Given this list of marker genes TTC28, ADTRP, LGALS3BP, LDOC1, MEGF6, MCF2L (MCF.2 cell line derived transforming sequence like), PIM2, CSGALNACT1 (chondroitin sulfate N-acetylgalactosaminyltransferase 1), ACVR2A, AKR1C1, DGKA, RAB3GAP1, C14orf132 (chromosome 14 open reading frame 132), PVT1, KANSL1L, R3HDM4, SASH1, KLF7, EEIG1, CREB3L1, FOXO1, CHMP7 (NCBI Gene Id 91782), ACVR2B, TRIB2, TNFRSF4, CRYAB, PTGIR, GPHN, IL6ST, EDAR, VAT1, MINDY1, LIMK2, IL1RAP, RPS6KA5, MORC4, BSDC1, EOLA2-DT, GAL3ST4, MEOX1 (NCBI Gene Id 4222), CTSB, ENGASE, CPA2, SLC16A5, PLAC4, NDRG2, TRAF3IP2, WNT7A, NPC2, ADGRE1, CFP, GPA33, LECT2, EEF1G, CORO1B, MAP3K3, EPS8, LTB, LGR5, FAM13A, CFAP44, ITGA6, RERE, VIPR1, LEF1, MAST4, N4BP1, MEIS3P1, EPHA1, RFPL3, MAN1C1, TPCN1, FHIT, C1orf105, LY96, PHKA2, EPHB6, PIM1, GABBR1, PLP2, PPEF2, SEMA3G (semaphorin 3G), HKDC1, TIAM1, ARHGEF11, FABP4, PLPP1, SSBP2, SLC8B1, FAXDC2, DPP4, TESPA1, RCAN3, FBLN5, DACT1, PDE4DIP, BCL2 (NCBI Gene Id 596), ICA1, EPHX2, CCR6, IDUA, TBC1D4, GPRASP1 (NCBI Gene Id 9737), SGSH, CLTCL1, LIMS2, GPR183, SIRT3, CYSLTR1, TAF4B, SELL, SPICE1, CCNI, PFKM, ZC4H2, KBTBD11, CRIP2, ACVR1, SULT1B1, COL4A3, KCNN1, TPD52L1, OBSL1, PDE8A, SLC22A17, MSRA, BIRC3, C6orf120, INF2, DDR1, NUMA1, CEP85, ANKRD55, HFE, GNAQ, PSG11, TBXAS1, ABCA1, AK5, FSCN3, SLC25A28, CCR7, EDEM3, MLPH, AQP3, IL7R, TNFRSF25, SORCS3, MAL, LUZP4, NAA11, NETO2, N4BP2L1, PFN2, CLN5, ALS2CL (ALS2 C-terminal like), CD59, TLR5, ANK3, OCRL, IL27RA, IL6R, LTBP3, KRT18, SLAMF1, KCNH2, TPM1, CYLD, TNNI3, ADAM19, CTSL, CACNA1I (calcium voltage-gated channel subunit alpha1 I), EPPK1, MANSC1, BAG3, PGLYRP4, PTGIS, ADD3, IL2RA, CACNA1G, DENND5A, C2CD2L, WDR73, RNASET2, DET1, AP3M2, DIS3, PLCL1, TRAT1, LRP6, SLC6A12, TSEN2, SLC16A10, C1orf115, F5, PTK2, ZNF507, GAS6, ADAM12, here is a description of the gene set: Human Gene Set: GSE45739_UNSTIM_VS_ACD3_ACD28_STIM_WT_CD4_TCELL_UP Genes up-regulated in CD4 T cells: unstimulated versus activated. It has been recently shown that N-ras plays a preferential role in immune cell development and function; specifically: N-ras, but not H-ras or K-ras, could be activated at and signal from the Golgi membrane of immune cells following a low level TCR stimulus. The goal of our studies was to test the hypothesis that N-ras and H-ras played distinct roles in immune cells at the level of the transcriptome. First, we showed via mRNA expression profiling that there were over four hundred genes that were uniquely differentially regulated either by N-ras or H-ras, which provided strong evidence in favor of the hypothesis that N-ras and H-ras have distinct functions in immune cells. We next characterized the genes that were differentially regulated by N-ras in T cells following a low-level TCR stimulus. Of the large pool of candidate genes that were differentially regulated by N-ras downstream of TCR ligation, four genes were verified in qRT-PCR-based validation experiments as being differentially regulated by N-ras (Dntt, Slc9a6, Chst1, and Lars2). Finally, although there was little overlap between individual genes that were regulated by N-ras in unstimulated thymocytes and stimulated CD4+ T-cells, there was a nearly complete correspondence between the signaling pathways that were regulated by N-ras in these two immune cell types. Since we were interested primarily in genes that were differentially regulated by N-ras following a low-level TCR stimulus, our microarray data comparison was between data from TCR-stimulated, WT CD4+ T-cells and from TCR-stimulated, N-ras KO CD4+ T-cells. Genes that were differentially regulated in the comparison between stimulated N-ras KO CD4+ T-cells and unstimulated N-ras KO CD4+ T-cells, as well as those genes that were differentially regulated in the comparison between stimulated WT CD4+ T-cells and unstimulated WT CD4+ T-cells were excluded from this analysis. To determine if N-ras and H-ras regulate different sets of genes in thymocytes, a comparison was made between the set of genes that were differentially regulated by N-ras in the vs. comparison and the set of genes that were differentially regulated by H-ras in the vs. comparison. studied in species Homo sapiens from publication Lynch SJ, Zavadil J, Pellicer A (PMID 23755101)